The following is a description of a gene set: from publication Tabula Muris Consortium (PMID 32669714) studied in species Mus musculus Mouse Gene Set: TABULA_MURIS_SENIS_LUNG_SMOOTH_MUSCLE_CELL_OF_THE_PULMONARY_ARTERY_AGEING, and this is the list of marker genes: Aqp1, S100a8, Cd74, H2-Aa, Clic4, H2-Ab1, Akap12, Sparcl1, Dcn, Gpihbp1